The following is a description of a gene set: Protein biosynthesis, transport or catabolism genes up-regulated in hyperploid multiple myeloma (MM) compared to the non-hyperploid MM samples. Hyperdiploid multiple myeloma (H-MM) is the most common form of myeloma. In this gene expression profiling study, we show that H-MM is defined by a protein biosynthesis signature that is primarily driven by a gene dosage mechanism as a result of trisomic chromosomes. Within H-MM, four independently validated patient clusters overexpressing nonoverlapping sets of genes that form cognate pathways/networks that have potential biological importance in multiple myeloma were identified. One prominent cluster, cluster 1, is characterized by high expression of cancer testis antigen and proliferation-associated genes. Tumors from these patients were more proliferative than tumors in other clusters (median plasma cell labeling index, 3.8; P < 0.05). Another cluster, cluster 3, is characterized by genes involved in tumor necrosis factor/nuclear factor-kappaB signaling and antiapoptosis. These patients have better response to bortezomib as compared with patients within other clusters (70% versus 29%; P = 0.02). Furthermore, for a group of patients generally thought to have better prognosis, a cluster of patients with short survival (cluster 1; median survival, 27 months) could be identified. This analysis illustrates the heterogeneity within H-MM and the importance of defining specific cytogenetic prognostic factors. Furthermore, the signatures that defined these clusters may provide a basis for tailoring treatment to individual patients. from publication Chng WJ, Kumar S, Vanwier S, Ahmann G, Price-Troska T, Henderson K, Chung TH, Kim S, Mulligan G, Bryant B, Carpten J, Gertz M, Rajkumar SV, Lacy M, Dispenzieri A, Kyle R, Greipp P, Bergsagel PL, Fonseca R (PMID 17409404) species: Homo sapiens Human Gene Set: CHNG_MULTIPLE_MYELOMA_HYPERPLOID_UP, and this is the list of marker genes: RSL24D1, UBA52, RPL7A, KLK3, EIF3J, MRPL34, RPS10P2 (ribosomal protein S10 pseudogene 2), RPL15, RPL4, RPL21, SCAMP5, RPLP1, UBA7, RPSA, RPL28, EIF3G, RPS15, RPL32, RPL29, RPL35, SNRNP70, RPL18, RPS23, RPS6, EIF4A2, RPS16, USP3, EEF1B2, HNRNPA1, QARS1, RPS9, RPL14, RPS14, RPS13, RPS17, IMP3, EEF2, NCBP2, RPS3, RPL37, RPLP2, RPL27A, EIF3K, CLTA, RPL36, FBL, EEF1G, NPM1, RPL35A, DHPS, HERC1, RPL13A, RPS19, RPL24